Given this list of marker genes TECTB, FXYD7, ATP6V1G1, FOXL1, HRCT1, ACKR3, LLGL1, NKAPL, H3-3B, TRIP4, MYO1G, LRRFIP1, YPEL5, NTF4, BRINP1, APOH, TSR2, H2AC6, NIT2, IFNA14, TMPRSS11E, RANGAP1, CCN4, TAFA1, DEXI, LAG3, C2orf88, POMC, PPM1K, ITGA3, VPS37D, ENSG00000280119 (TEC), DDX60L, SMCR8, ARHGEF16, PELI1, SLC5A8, NXPH3, VRK3, GAK, ACHE, INO80B, RHEB, TXN, NPHS1, NEUROD1, AKNAD1, MYL12A, LINC00939 (NCBI Gene Id 400084), SRP19, FXYD6, ZNF615, CD274, TAMALIN, ILF3-DT, TMEM74B, SEMA4D, DLGAP1-AS1, FBXO22, BORCS8, LINC02175, RRP7A, MAGOH2P, CCDC137, MAIP1, KIR2DS2, ISG20, PARP10, TCP11L1, SLC16A1-AS1, SERPINB1, CDCA5 (NCBI Gene Id 256676), XPO1, GTF3C6, SLAMF7, ALPG, HNRNPD, RFPL1, LINC01532, STIM2, LGALS3BP, BANP, EXOSC3, ENSG00000229727, CTPS2, CBR1, XRCC2, MEGF10, C9orf85, RPA2, PRMT8, ZNF582-DT, ATP6V1E1, BTN2A1, ZNF350, RNF8, MIX23P3, SLC34A1, XKR8, RIOX1, ADAMTS16, TRMT10B, MRPS30, HHIPL2, OR51I1, SQSTM1, MAP7D1, CATSPER3, KCNQ2, CLIC1, CRX, PARP6, PPP4R3C (protein phosphatase 4 regulatory subunit 3C), KIFAP3, CYP4X1, BCL7B, TBPL1, NOL7, BST2, TCAP, PPFIBP2, KIF18A, ZNF92, PSMA3, DNAJC22 (NCBI Gene Id 79962), NPFFR1, STAC3, ABTB2, LINC01123, HUNK, EBI3, INSM2, LRRC61, CLDN7, NR6A1, CFAP95, RTP4, RANGRF (RAN guanine nucleotide release factor), ISCU, GTF2E1, SSTR1, NFE2L1, KLHL28, PACRG, PEX3, MRM3, LINC00626, MARCHF11-DT, ZNF479, UNC13D (unc-13 homolog D), INTS4P1, REPIN1, ZNF486, MRPL18, SLC31A2, NINJ1, S100A11, SLCO5A1, UQCC6, PML, ZNF267, AVIL, FGFBP1, FAM149A, BTLA, ZBTB2, TSGA10IP, ZBP1, FBXL12, RELA, AIMP1, SLC35A4, SHFL, PCYT1B, OSBP2, SFT2D3, BTN3A1, TRIM3, RANBP6, PSMC3IP, EIF1B-AS1, TRIM6, DEDD, MFAP1, NEAT1, IFIH1, RAB8A, HLA-C, UBE2Z, MVK, IL18RAP, ANXA2P2, TRIM38, TMEM119 (transmembrane protein 119), here is a description of the gene set: Human Gene Set: GSE16385_IL4_VS_ROSIGLITAZONE_STIM_MACROPHAGE_DN Genes down-regulated in macrophages (12h): IL4 versus rosiglitazone. studied in species Homo sapiens Human CD14 positive monocytes were purified from healthy volunteers’ blood and cultured in vitro for 4, 12, 24, 72 hours. While culturing, macrophages were activated alternatively with interleukin-4 (IL-4 100 ng/ml) or classically with interferon-gamma (IFNg 100 ng/ml)+tumor necrosis factor (TNF 50 ng/ml) or left without activation. Simultaneously, macrophages were also treated with vehicle (DMSO:ethanol) or 1mM synthetic PPARg agonist, Rosiglitazone. We used Affymetrix microarrays (U133Plus 2.0) to analyze activation and PPARg-induced gene expression changes. from publication Szanto A, Balint BL, Nagy ZS, Barta E, Dezso B, Pap A, Szeles L, Poliska S, Oros M, Evans RM, Barak Y, Schwabe J, Nagy L (PMID 21093321)